The following is a description of a gene set: This event has been computationally inferred from an event that has been demonstrated in another species.<p>The inference is based on the homology mapping from PANTHER. Briefly, reactions for which all involved PhysicalEntities (in input, output and catalyst) have a mapped orthologue/paralogue (for complexes at least 75% of components must have a mapping) are inferred to the other species. Reactome Pathway: Synaptic adhesion-like molecules electronically inferred by orthology from the curated human pathway part of: Protein-protein interactions at synapses studied in species Mus musculus, and this is the list of marker genes: Flot2, Grin2b, Grin2c, Flot1, Lrfn2, Dlg4, Lrfn3, Ptprf, Lrfn1, Dlg3, Grin2a, Rtn3, Grin1, Lrfn4, Ptprs, Grin2d